Given this list of marker genes APOA1, DGAT2, CETP, SEL1L, GCK, APOA2, APOC2, LDLR, PLTP, APOA5, LRP1, MTTP, LIPC, ACSS1, FAS, PDIA2, GPIHBP1, APOA4, LCAT, LMF1, LPL, GCKR, here is a description of the gene set: studied in species Homo sapiens Human Gene Set: WP_FAMILIAL_HYPERLIPIDEMIA_TYPE_4 Familial hyperlipidemia type 4